The following is a description of a gene set: RHOF GTPase cycle Human Gene Set: REACTOME_RHOF_GTPASE_CYCLE species: Homo sapiens, and this is the list of marker genes: BAIAP2L1, ARHGAP12, FARP1, SLC4A7, SNAP23, STEAP3, MCAM, CAPZB, ADD3, ARHGAP1, ARHGAP32, DIAPH3, ESYT1, SRGAP2, MTMR1, ARHGAP39, RAB7A, FAM169A, BAIAP2L2, DIAPH2, CAV1, MYO9B, BASP1, SYDE1, SENP1, PIK3R2, POTEE, ACTB, SOWAHC, ARHGAP5, RHOF, VAMP3, TMPO, AKAP12, ARHGAP21, TOR1AIP1, DIAPH1, DEPDC1B, ACTN1, PIK3R1, LMNB1, VANGL1